Given this list of marker genes BNIP3, MSTO1, VAT1, PID1, MTCH2, OMA1, MIEF1, PLD6, YME1L1 (NCBI Gene Id 115724), TFRC, ZDHHC6, HUWE1, ADCK1, MUL1, PRKN, here is a description of the gene set: Human Gene Set: GOBP_REGULATION_OF_MITOCHONDRIAL_FUSION studied in species Homo sapiens Any process that modulates the frequency, rate or extent of merging of two or more mitochondria within a cell to form a single compartment.